Given this list of marker genes CEP55, RELN, SEMA3A, WNT4, CMPK1, HSPG2, KRTAP4-6, CCNJL, FAM135A, SGK1, AMMECR1, SYNJ1, NSG1, PIP4P1, SALL4, PAFAH1B2, ANKS1A, PEX13, KCNJ2, PRRC2C, MYRIP, ANLN, MASP1, COPS7B, SH3GL2, FASN, NAV1, MAP3K9, RSBN1, ZC3H13, RBM6, UNC5D, CDHR1, SUMO3, FAM110C, HMBOX1, DLEU7, CD3E, C2orf42, RBM12, MAMSTR, TRIP11, PDZD8, RNF144B, CHAC1, DCLK1, PDK4, BMPR1A, ISM2, TMCC1, STRADB, C1orf21, DPY19L4, USP3, EZH1, RAB30, TMEM154, SEMA6D, LATS1, AGO4, EPC1, ANO3, LARGE2, SUZ12 (NCBI Gene Id 23512), BCL11B, CLUH, ASH1L, NRN1, IGF1R (NCBI Gene Id 51049), UBE2V1, SYPL1, RFK, TTC14, G2E3, GFAP, ACOX1, ELL, SAV1, CPD, TARBP2, VEGFA, E2F3, MIB1, SLC9A6, NOS1, ZSCAN31, CDCA4, ANKUB1, WNK3 (NCBI Gene Id 65267), IGF2R, CHEK1, FERMT2, ZBTB44, OOEP, CXCR5, ADAMTS6, ZBTB20, TMEM74B, STK33, RET, SPTLC1, BZW1, BTAF1, SMAD7, WNT7A, CHUK, LAMC1, SPAG7, SCOC, DYNC1LI2, SVIP, TUBA4A, CBX4, ZNF691, CARM1, YRDC, CYP2S1, LGR5, SYT4, PNPLA6, KCNK10 (NCBI Gene Id 54430), SOX6, G0S2 (G0/G1 switch 2), SEMA3D, PCDH17, FGFR1, SLC6A11, PPT2, CASK, BCL2L2, UROS, EPHB2, SMURF1, OTX1, CDC37L1, QKI, AMOT, TRANK1, CAPRIN1, NUP50, RNF10 (ring finger protein 10), WWC1, GHR, SSR1, SERBP1, SLC20A2, ATXN7L3B, OMG, CCDC6 (NCBI Gene Id 8030), ACVR2A, RASEF, SLIT2 (NCBI Gene Id 9353), FAM89A, SSTR3, RUNDC3B, FLT3, RS1, BCL7A (BAF chromatin remodeling complex subunit BCL7A), KPNA3, HSPA4L, SEMA5B, USP42, MCU, NAA25, SYNRG, NCS1, LRIG2, SAMD10, SLC4A4, PIP4P2, ADRB2, LITAF, ARMH4, ZNRF2 (zinc and ring finger 2), MAN2A2, TFAP2A, ARHGAP32, SHOC2 (NCBI Gene Id 8036), JARID2, KIF3B, ENSG00000275993, ELAC1, SON, PCDH9, SEL1L3, DMPK, AXIN2, PTPRR, ZDHHC15 (zinc finger DHHC-type palmitoyltransferase 15), USP31, CREBRF, FGF2, MOV10, PABIR2, STOX2, FBXO21, CASR, ROCK2, RICTOR, SPRYD3, EXT2, CDC42SE2, SPRED1, EDA (ectodysplasin A), SKI, CDC27, EGLN1, ADAMTS3, USP15 (ubiquitin specific peptidase 15), SUCO, APLN, SRPRA, COL12A1, ANKRD46, ST8SIA3, CLOCK, CCND1, BAG4, TRIM66, SETD3, PCMT1, ZC2HC1A (NCBI Gene Id 51101), MBNL2, TBL1XR1, FGF7, DDX3X, IL7R, PHF19, ZNF622, SYT3, SLC11A2 (NCBI Gene Id 4891), GNAT1, LRIG1, SIPA1L2, PLAG1, WNT3A, PLXNA4, SEC24A, PPP6R3, SIRT4, DCP1A, SLC2A14, SESTD1, MGAT4A, KIF21A, CFAP45, XPO7, IVNS1ABP (NCBI Gene Id 51489), EYA1, CLCN4, INSR, CCDC88C, RUNX1T1, LSM11 (LSM11, U7 small nuclear RNA associated), YTHDC1, DEPDC4, CNOT6L, ACSL4, ILDR2, NSMF, UBE4A, TMEM245, RAB9B, GLS2, FBXL20, RAD50, TNRC6B (NCBI Gene Id 23112), SEPTIN2, DLL1, LRRN3, PTCH1, COBLL1, CCNT1, CLDN12, KCNN4, AMOTL1, ZNF548, FAM91A1, TMEM100, ZMYM2, ARFGAP2, FAM133B, IARS1, SLC2A3, GALNT7, MKNK1, RREB1, HELZ, VTI1B, AKT3, MYB, PELI2, RAB9A, SLC36A1, SNTB2, POU2F1, ZMAT3, NRP2, HEPHL1, ATG14, MYEF2, ARHGAP12, KDSR, MYO5A, PAG1, USP25, ZNF367, ABHD2, HIGD1A, GPR63, DENND1B, CDK5R1, GCC2, TCAIM, UBFD1, ATG13, IPPK, PTPRD, ADGRL1, FGF9, GPN1, MEX3C, AMER1, USP44, CBX2, PTH, CSDE1 (NCBI Gene Id 7812), ATF6, RPS6KA6, HECTD4, CBX6 (chromobox 6), CDK17, RIMKLB, DENND4A, SLC12A2, RASSF8, SOCS6, ATG9A, CD80, NECTIN1, WIPI2, EPB41L4B, KIF5B, MTFR1L, ABCF3, ZBTB34, PPP1R11, PDE3B, DNAJA2, GABARAPL1, CACNA2D1, TGIF2, MAP3K13, ETNK1, NR2C2, NHLRC2, YWHAH, SOBP, DMTF1, PRDM4, DENND2C, RBPJ, TMEM268, UBE4B, KIF1B, UNC13A, CPEB3, NUFIP2, NRBP1, HIPK2, UBN2, NOTCH2, STXBP3, UTP25, CCND2, RETREG2, SCN8A, HMGA1, BTRC, TBPL1, RARB, TMEM178B, KRTAP11-1, ISLR, CHPT1, SESN1, CACUL1, KIF23, TRAM1, ARHGAP20, ARIH1, RORA, DNAJB4, RIF1 (replication timing regulatory factor 1), CAPZA2, ZNF275, FNTA, HECTD1, PLXNC1, RECK, TNFSF13B, ZNF449, PRKAR2A, UBQLNL, CDK8, ZNHIT6, TSC22D2, PTPN4, TMEM199, PPP2R1B, MEOX2, SIK1, DYRK1B, NOB1, ST7L, ARPP19, PIK3R1, SMIM13, ZFHX4, OGT, LURAP1L, CPSF7, SALL3, GSTCD, STXBP5 (syntaxin binding protein 5), C12orf76, MAP7, KCTD8, FAM81A, AVL9, PLPP1, GALNT13, KANK1, RTN4, ARHGDIA, ZBTB39, FOXK1, DIXDC1, MTMR3, UNC80, DRD1, RASGEF1B, NAPG, GATAD2A, TGFBR3, STXBP1, ELMOD1, HOXA10, LRP6, RSPO3, MAP2K1, RBBP6, TLK1, KLHL2, SYDE2 (NCBI Gene Id 84144), LUZP1 (NCBI Gene Id 7798), RNF217, SNX16, CUX1, ACTR2, ARL2, MYO5B, PPM1E, ANXA11, PPM1A (NCBI Gene Id 5494), CPEB2, LAMP3 (lysosomal associated membrane protein 3), PAPPA, VPS4A, ABL2 (ABL proto-oncogene 2, non-receptor tyrosine kinase), TENM2, PISD, LRRK1, GRM7, ZFHX3, PTPN3, HTR2A, UBE2Q1, WBP11, CDC25A, CSRNP1, AREL1, UBR3, PEDS1-UBE2V1, CCNE1, WEE1, CD47 (CD47 molecule), N4BP1, SMURF2, LDLRAD2, PLRG1, CYB561A3, MYBL1, TMEM135, AHCYL2, RAB11FIP2, CEP85L, TFCP2L1, SLC25A37, MED26, TBP, CD2AP, HERC6 (NCBI Gene Id 55008), SALL1, PDIA6, VPS33B, ATXN7L2, RBM24, NF1, MKX, SLC13A3, DDX3Y, MOB3B (NCBI Gene Id 79817), PLEKHA1, ZNRF3, ATXN2, ATXN1L, COP1, SLC39A10, MNT, CACNA1E, TLL1, TRABD2B, IHH, ARMCX2, CC2D1B (NCBI Gene Id 84499), CHD2, ATXN7L1, IPO7, TMC7, NFATC3, GOLGA1, ATXN7L3, CYP26B1, SPTBN2, PARVA, C1QL3, MFN2, DESI1, MIDEAS (NCBI Gene Id 91748), TMEM183A, GPATCH8, SEH1L, MOB4, SLC35G1, GGA3, ENAH, RGMA, JPH3, AK4, IKBKB, LRP2, EPHA7, ZBTB46, CHIC1, PIAS2, KCNG4, EXOC3L2, LYPLA2, FBXW7, P3H2, KIF5C, GAREM1, ELL2 (elongation factor for RNA polymerase II 2), SREK1 (splicing regulatory glutamic acid and lysine rich protein 1), SNRPB2, ZCCHC3, CMC4, AGO1, CCDC83, RAD23B (NCBI Gene Id 5887), MYLK, TAB3, IFT74, RPS6KA3, ZCCHC2, ARL3, PAFAH1B1, BTG2, ACVR2B, HTR4, RFX3, here is a description of the gene set: Human Gene Set: MIR15A_5P studied in species Homo sapiens Genes predicted to be targets of miRBase v22 microRNA hsa-miR-15a-5p in miRDB v6.0 with MirTarget v4 prediction scores > 80 (high confidence targets). from publication Chen Y, Wang X (PMID 31504780)